The following is a description of a gene set: Human Gene Set: GOBP_SPLICEOSOMAL_CONFORMATIONAL_CHANGES_TO_GENERATE_CATALYTIC_CONFORMATION studied in species Homo sapiens Structural rearrangements of the spliceosome complex, containing RNA to be spliced, to generate a catalytic conformation., and this is the list of marker genes: XAB2, SNRNP200, YJU2, PRPF18, ISY1